Given this list of marker genes BRAF, FLCN, MAP2K1 (mitogen-activated protein kinase kinase 1), ABCA3, ADAMTS2, SMAD3, TGFBR2, SMAD2, SFTPC, THSD4, ATP6V1E1, PKHD1, RAI1, DZIP1L, SFTPB, ADAMTS3, CCR2, COL3A1, CAV1, NRAS, here is a description of the gene set: species: Homo sapiens Pneumothorax occurring without traumatic injury to the chest or lung. Spontaneous pneumothorax Human Gene Set: HP_SPONTANEOUS_PNEUMOTHORAX